The following is a description of a gene set: Genes having at least one occurrence of the motif GGGGCGGGGC in the regions spanning 4 kb centered on their transcription starting sites. This matches the SP1 transcription factor binding site V$SP1_Q6_01 (v7.4 TRANSFAC). studied in species Homo sapiens Human Gene Set: SP1_Q6_01, and this is the list of marker genes: HOXC13, SLC8B1, ASPHD1, ST6GALNAC3, ELL, PIAS1, TBCB, ZNF768 (zinc finger protein 768), LIMA1, INPPL1, ERC1, MAP4K2, EPS8L2, KAT2A, PTOV1 (NCBI Gene Id 53635), PIGV, CAMK2G, CSNK1D (casein kinase 1 delta), CACNA1A (calcium voltage-gated channel subunit alpha1 A), STARD13, XPR1, PIP4K2B, SLC46A1, CLPTM1, SMARCE1, UBE2O, SPATA6, SEPTIN4, TKFC (NCBI Gene Id 26007), CHKA, NAV1, NFYB, STMN1, ECE1, PLPPR2, CPD, BCL2L2 (BCL2 like 2), SIPA1, UNC45A, TGFB1, SEC24C, PHF23, SLC35F5, EFCAB13, CDK5R1, EVI5L, BCL7C, MIR22HG, NECTIN2, LMNTD2, GIPC1, KTN1, PITPNM1, IQGAP1, ZNF48, CSPG4, NET1, KLF11, TAGLN2, DET1, OAZ2, RELA, EMSY, RCOR2, SENP1, COA7, FOSB (FosB proto-oncogene, AP-1 transcription factor subunit), ANKRD12, ADCK1, POLR1G, LZTS2, SLC2A1, VASP, RND2, KICS2, NPAS4, CRY1, MYO1C, DUOX1, UGP2, POLR2I, ELAC2, NFAT5, LOXL4, RBFOX1, SYT9, PTCH2, HTR7, CADM1, LYRM1, TIMELESS, ADAM15, RAB26, IDH3A, TMUB2, PTPN2, PEX14, FKBP8, MAPK7, DGKA, TEAD2, LDB1, CDC37, MAP3K6, PCYT2, RABEP2, MAP3K11, PPP1R36, SLC30A3, ME3, SPAST, C1orf43, SNAPIN, APLP1, FGF11, ROM1, CPSF7, PARD6A, PUSL1, RHOG, SCYL1, OTX1, TIPRL, DCAF4, ULK1, CALM3, RAB35, RASSF7, IRX3, S1PR5, FLII, PPM1J, PHOX2A, C11orf68, SMARCD1, ZNF524, PGM2L1, HCN4, ADAM17, DDB1, PSMC6, KANK2, DRAP1, NUFIP2, CYP26B1, BCL9L, WDR81, LLGL2, PDIK1L, SMOC1, GPR3, PRMT1, POLR3E, TAGLN, RAB2B, YRDC, TMEM150A, SLC18A3, AP5B1, SYNRG, TAOK2, BTBD10, TMED10, ACE, GABARAPL2, ACSF2 (NCBI Gene Id 80221), NTF4, GLTP, VAMP2, PITPNA, LRRC8E, SRSF2, ACBD5, CXCL12, CORO1C, EEF1DP3, EPS15, UBALD2, CHAT (choline O-acetyltransferase), NOTCH3, ADSS2, APLP2, TCF4, GGN, EFNA3, CBLN1, CCDC85B, RHBDL3, C2CD2L, KCNQ4, EFNB3, KAT5, RELB, CTTNBP2NL, NXPH4, FHIP1B, GOLGA3, HES7, AGBL5, C2CD5, PER1, MYO19, HID1, PIGN, ERO1B, SHMT1, PLEKHM1, DNAJC4, PCGF2, ANP32A, EML3, KLF5, PIAS3, GRB2, TMEM256, GAS7, ACER3, SDHAF2, UPF2, SLC1A2, SUV39H2, IGF2BP1, ATP2A2, TLX2, AJUBA, C1orf122, CNNM4, MAZ, MAP2K7, BRI3BP, WNT2B, ELAVL3, MIEF2, FRMD5, LASP1, PIGW, ABCC1, NLK, SERINC2, ASCL2, PAK4, MARCKSL1, HSPB9, TRIM28, RTF1, PGF, KLF2, FDX1